The following is a description of a gene set: Human Gene Set: HP_ADRENOCORTICAL_CARCINOMA Adrenocortical carcinoma species: Homo sapiens A malignant neoplasm of the adrenal cortex that may produce hormones such as cortisol, aldosterone, estrogen, or testosterone., and this is the list of marker genes: APC, CDKN2B, MDM2, MEN1, KCNQ1 (NCBI Gene Id 3784), CTNNB1, TP53, CDKN2A, CDKN1B, ZNRF3, KCNQ1OT1, CDKN2C, PRKAR1A, IGF2, CDKN1A, TERT, CDKN1C, CHEK2